Given this list of marker genes RPA2, PCNA, RFC2, POLE3, RFC1, POLD3, POLB, RPA1, PARP1, FEN1, ADPRS (ADP-ribosylserine hydrolase), POLD2, APEX1, RPA3, POLD1, POLD4, RFC3, POLE4, PARG, POLE2, PARP2, RFC5, RFC4, POLE, LIG1, here is a description of the gene set: Resolution of AP sites via the multiple-nucleotide patch replacement pathway species: Homo sapiens Human Gene Set: REACTOME_RESOLUTION_OF_AP_SITES_VIA_THE_MULTIPLE_NUCLEOTIDE_PATCH_REPLACEMENT_PATHWAY